Given this list of marker genes F9, here is a description of the gene set: A deficiency or dysfunction of factor IX (FIX) caused by mutations in the F9 gene is associated with a blood clotting disorder hemophilia B (HB). The FIX protein level may be decreased in the circulation by F9 mutations affecting FIX protein synthesis, stability, or secretion (Kurachi S et al. 1997; Enjolras N et al. 2004; Branchini A et al. 2013, 2017; Tajnik M et al. 2016; Odaira K et al. Reactome Pathway: Defective F9 secretion part of: Defective factor IX causes hemophilia B studied in species Homo sapiens